The following is a description of a gene set: Human Gene Set: ABBUD_LIF_SIGNALING_2_UP from publication Abbud RA, Kelleher R, Melmed S (PMID 14576184) Leukemia inhibitory factor (LIF) mediates the hypothalamo-pituitary-adrenal stress response. Transgenic mice overexpressing LIF in the developing pituitary have altered pituitary differentiation with expansion of corticotropes, maintenance of Rathke's cleft cysts, and suppression of all other pituitary cell types. Affymetrix GeneChips were used to identify modulators of LIF effects in corticotrope (AtT-20) and somatolactotrope (GH(3)) cells. In addition to genes known to respond to LIF in corticotrope cells, corticotrope-specific changes were also observed for genes involved in glycolysis and gluconeogenesis, transcription factors, signaling molecules, and expressed sequence tags. Two transcription factors identified, CCAAT/enhancer-binding protein beta (C/EBPbeta) and glial cell-derived neurotrophic factor (GDNF)-inducible factor (GIF), dose-dependently induced expression of the rat POMC promoter when overexpressed in AtT-20 cells. LIF further induced POMC transcription with C/EBPbeta, but not with GIF. C/EBPbeta also induced expression of the SOCS-3 promoter that was further enhanced by cotreatment with LIF. However, GIF did not affect SOCS-3 expression. These results indicate that C/EBPbeta and GIF are downstream effectors of LIF corticotrope action. LIF also stimulates the expression of inhibitors of its actions, such as SOCS-3 and SH2 domain-containing tyrosine phosphatase-1. alpha(2)-HS-glycoprotein (AHSG)/fetuin, a secreted protein that antagonizes bone TGFbeta/bone morphogenic protein signaling, was induced by LIF in a signal transducer and activator of transcription-3-dependent fashion. Pretreatment with AHSG/fetuin blocked LIF-induced expression of the POMC promoter independently of SOCS-3. Thus, using GeneChips, C/EBPbeta and GIF have been identified as novel mediators and AHSG/fetuin as an inhibitor of LIF action in corticotropes. species: Rattus norvegicus Genes up-regulated in GH3 cells (pituitary cancer) after treatment with LIF., and this is the list of marker genes: ATP1B1, PTPRO, PPP2R2B, NRP1, COL11A1, FGFR1, EZR, DIO2, JUNB, PFKP, DAB2, GPX2, DCN